Given this list of marker genes Il33, Traf6, Il1rap (NCBI Gene Id 319228), Irak4, Irak1, Myd88, Map3k7, Il1rl1, here is a description of the gene set: studied in species Mus musculus The series of molecular signals initiated by interleukin-33 binding to its receptor on the surface of a target cell, and ending with the regulation of a downstream cellular process, e.g. transcription. Mouse Gene Set: GOBP_INTERLEUKIN_33_MEDIATED_SIGNALING_PATHWAY